The following is a description of a gene set: from publication Cui A, Huang T, Li S, Ma A, Pérez JL, Sander C, Keskin DB, Wu CJ, Fraenkel E, Hacohen N (PMID 38057668) Cytokines mediate cell-cell communication in the immune system and represent important therapeutic targets. A myriad of studies have highlighted their central role in immune function, yet we lack a global view of the cellular responses of each immune cell type to each cytokine. To address this gap, the authors created the Immune Dictionary, a compendium of single-cell transcriptomic profiles of more than 17 immune cell types in response to each of 86 cytokines (>1,400 cytokine-cell type combinations) in mouse lymph nodes in vivo. A cytokine-centric view of the dictionary revealed that most cytokines induce highly cell-type-specific responses. For example, the inflammatory cytokine interleukin-1β induces distinct gene programmes in almost every cell type. A cell-type-centric view of the dictionary identified more than 66 cytokine-driven cellular polarization states across immune cell types, including previously uncharacterized states such as an interleukin-18-induced polyfunctional natural killer cell state. studied in species Mus musculus Genes negatively differentially expressed in cell type: γδ T cell upon treatment with cytokine: IL-21 in mouse lymph nodes in vivo. Mouse Gene Set: CUI_T_CELL_GD_IL21_RESPONSE_DN, and this is the list of marker genes: Fos, Hspa1b, Uba52, Pnrc1, Ubc, Hspa1a, Nr4a1, Dusp1, Fosb, Btg2 (BTG anti-proliferation factor 2), Klf2, Jun, Zfp36l2, Rhob, Junb